Given this list of marker genes Ptger3, Nos1, Ptpmt1 (protein tyrosine phosphatase, mitochondrial 1), Mtnr1a, Sirt4, Rest, Stxbp5l, Ppp3ca, Kcnb1, Srebf1, Fkbp1b, Uts2, Gnaz, Mtnr1b, Psmd9, Kcnj6 (potassium inwardly-rectifying channel, subfamily J, member 6), Prkn (NCBI Gene Id 50873), Rptor, Ghrl, Inhbb (inhibin beta-B), Midn, Jagn1, Crhr2, Ptprv, F2rl1, Hadh, Klf7, Mup2, Eny2, Pim3, Mup3, Pde8b, Mup4, Ffar3 (NCBI Gene Id 233080), Kcnj11, Acvr1c, Ccn3, Irs1, Fam3d, Tbc1d1 (TBC1 domain family, member 1), Ucp2, Drd2, Sytl4 (synaptotagmin-like 4), Mup1, Chga, Npff, Gnai1, Mup5, Kcnq1, Ffar2, Pde3b, Abcc8, Ghsr, Sfrp1, Fbn1, Ndufaf2, Pde4c, Gnao1, Adra2a (adrenergic receptor, alpha 2a), Map4k4, Mup11, Pde1c, Ptpn11, Vsnl1, Hmgcr, Pfkl, Foxo1, here is a description of the gene set: Any process that stops, prevents, or reduces the frequency, rate or extent of the regulated release of insulin. species: Mus musculus Mouse Gene Set: GOBP_NEGATIVE_REGULATION_OF_INSULIN_SECRETION